The following is a description of a gene set: Human Gene Set: GOCC_ALPHA_KETOACID_DEHYDROGENASE_COMPLEX A multi-enzyme complex that catalyzes the oxidative decarboxylation of an alpha-ketoacid - pyruvate, a branched-chain alpha-ketoacid or alpha-ketoglutarate (also known as 2-oxoglutarate). The complex comprises multiple copies of three enzymes referred to as E1, E2 and E3: a dihydrolipoyl transacylase (E2) forms the core of the complex, with an alpha-ketoacid dehydrogenase (E1) and a dihydrolipoamide dehydrogenase (E3) attached through non-covalent bonds. The E1 and E2 components are specific to different alpha-ketoacid dehydrogenase complexes, whereas the E3 component is the same. Additional proteins may also be present. species: Homo sapiens, and this is the list of marker genes: ABHD11, DHTKD1, DLST, OGDH, OGDHL, PDHX, PDK2, PDHA1, BCKDK, KAT2A, DBT (dihydrolipoamide branched chain transacylase E2), PDK1, DLAT, PDHB, PDHA2, BCKDHB, BCKDHA, DLD, KGD4